The following is a description of a gene set: Mouse Gene Set: GOBP_POSITIVE_REGULATION_OF_VASCULAR_PERMEABILITY species: Mus musculus Any process that increases the extent to which blood vessels can be pervaded by fluid., and this is the list of marker genes: Ucn, Ptp4a3, Trpv4, Tgfb1, Angpt1, Capn1, Tjp3, Ocln (occludin), Bmp6, Apoe, Pde3a, Cxcr2, Pde2a, Vegfa (NCBI Gene Id 22339), Fgfbp3, Tacr2, Tjp1, Tacr1, Ccl4, Tjp2, Il18